The following is a description of a gene set: Mouse Gene Set: GOMF_RS_DOMAIN_BINDING Binding to an RS domain of a protein; RS domains are usually highly phosphorylated and characterized by the presence of arginine (R)/serine (S) dipeptides. The RS domain promotes protein-protein interactions and directs subcellular localization and, in certain situations, nucleocytoplasmic shuttling of individual SR proteins. They also play a role in splicing. species: Mus musculus, and this is the list of marker genes: Rbm39, Srsf5, Luc7l, U2af1, Srsf1, Son